The following is a description of a gene set: studied in species Homo sapiens Abnormal light- and dark-adapted electroretinogram An abnormality of the combined rod-and-cone response on electroretinogram. Human Gene Set: HP_ABNORMAL_LIGHT_AND_DARK_ADAPTED_ELECTRORETINOGRAM, and this is the list of marker genes: CERKL, POMGNT1, RHO, RPE65, TTC8, ADAR, PROM1, RGR (NCBI Gene Id 5995), IDS, MFRP, CLRN1 (clarin 1), GUCY2D, MT-ATP6, IMPDH1, CYP4V2 (cytochrome P450 family 4 subfamily V member 2), NR2E3, IDH3B, PRPH2, CACNA1F, AIPL1, RP1, ZNF513, PDE6B (phosphodiesterase 6B), ALG3, ACOX1, RP9, RPGRIP1, NUP54, USP45, RDH5, PCYT1A, MCOLN1, LRAT, NUP62, BEST1, PPT1, RLBP1, LARGE1, SAG